The following is a description of a gene set: Human Gene Set: KEGG_MEDICUS_REFERENCE_NUCLEAR_INITIATED_ESTROGEN_SIGNALING_PATHWAY Nuclear-initiated estrogen signaling pathway. Pathway ID: N00286. Pathway type: Reference. Pathway class: nt06323 KISS1-GnRH-LH/FSH-E2 signaling. studied in species Homo sapiens Pathway Definition from KEGG: E2 -> ((ESR1/2)+(NCOA1/2/3)) => (BCL2,EBAG9,KRT19,CTSD,TFF1,PGR), and this is the list of marker genes: NCOA2, ESR2, TFF1 (NCBI Gene Id 7031, trefoil factor 1), ESR1, PGR (progesterone receptor), EBAG9, CTSD, KRT19, NCOA3, BCL2, NCOA1